The following is a description of a gene set: PGK1, PKM2, KHKC/KHKA acting as protein kinases studied in species Homo sapiens Human Gene Set: WP_PGK1_PKM2_KHKCKHKA_ACTING_AS_PROTEIN_KINASES, and this is the list of marker genes: PKM, PRPS1, AKT1S1 (AKT1 substrate 1), BUB3, H2AX, PAK2, H3-3A, KHK, SNAP23, H3-3B, PDK1, PGK1, MYL2, BECN1, STAT3